Given this list of marker genes KIF15, TBC1D2B, FOCAD, PIGS, FOXG1, MECP2, SLC19A3, IQSEC2, SMC1A, GABBR2, SLC18A2, PSAT1 (phosphoserine aminotransferase 1), ALG9, CDKL5, NTNG1, PHGDH, PSAP, GALC, here is a description of the gene set: Inappropriate crying Human Gene Set: HP_INAPPROPRIATE_CRYING species: Homo sapiens Uncontrolled episodes of crying occur without any apparent motivating stimuli.